Given this list of marker genes Folr1, Edn1, Twist1, Ednra, Cdc42, Sema3c, Nrp1, Eng, Pitx2, Bmp7, Bmp4, Hand2, here is a description of the gene set: The orderly movement of a neural crest cell from one site to another that will contribute to the morphogenesis of the outflow tract. Mouse Gene Set: GOBP_CARDIAC_NEURAL_CREST_CELL_MIGRATION_INVOLVED_IN_OUTFLOW_TRACT_MORPHOGENESIS species: Mus musculus